Given this list of marker genes GRB2, HGF, MET, PTPN11, GAB1, here is a description of the gene set: Human Gene Set: REACTOME_MET_ACTIVATES_PTPN11 species: Homo sapiens MET activates PTPN11